Given this list of marker genes Selenow, Il4, Chil3, Rplp0 (NCBI Gene Id 64336), Retnla, Sod2, Selenop, Alad, Selenov, Selenom, Ptgs2, Hpgds, Il13, Gip, Gpx1, Maob, Gstt1, here is a description of the gene set: species: Mus musculus Any process that results in a change in state or activity of a cell or an organism (in terms of movement, secretion, enzyme production, gene expression, etc.) as a result of a stimulus from selenium ion. Mouse Gene Set: GOBP_RESPONSE_TO_SELENIUM_ION